The following is a description of a gene set: Human Gene Set: WP_CEREBRAL_ORGANIC_ACIDURIAS_INCLUDING_DISEASES species: Homo sapiens Cerebral organic acidurias, including diseases, and this is the list of marker genes: L2HGDH (L-2-hydroxyglutarate dehydrogenase), D2HGDH (NCBI Gene Id 728294), ADHFE1, IDH2, ALDH7A1, GCDH, MDH2, ACY1